The following is a description of a gene set: species: Homo sapiens Human Gene Set: HP_POST_PARTUM_HEMORRHAGE Significant maternal hemorrhage/blood loss following deilvery of a child. Post-partum hemorrhage, and this is the list of marker genes: F10, DTNBP1, TPM4, F7, SERPINE1, F13B, F5, IKZF5, KIF23, RACGAP1, F8, DIAPH1, F13A1, F2